The following is a description of a gene set: species: Mus musculus Genes positively differentially expressed in cell type: cDC2 (conventional dendritic cell type 2) upon treatment with cytokine: NP in mouse lymph nodes in vivo. Cytokines mediate cell-cell communication in the immune system and represent important therapeutic targets. A myriad of studies have highlighted their central role in immune function, yet we lack a global view of the cellular responses of each immune cell type to each cytokine. To address this gap, the authors created the Immune Dictionary, a compendium of single-cell transcriptomic profiles of more than 17 immune cell types in response to each of 86 cytokines (>1,400 cytokine-cell type combinations) in mouse lymph nodes in vivo. A cytokine-centric view of the dictionary revealed that most cytokines induce highly cell-type-specific responses. For example, the inflammatory cytokine interleukin-1β induces distinct gene programmes in almost every cell type. A cell-type-centric view of the dictionary identified more than 66 cytokine-driven cellular polarization states across immune cell types, including previously uncharacterized states such as an interleukin-18-induced polyfunctional natural killer cell state. Mouse Gene Set: CUI_CDC2_NEUROPOIETIN_RESPONSE_UP from publication Cui A, Huang T, Li S, Ma A, Pérez JL, Sander C, Keskin DB, Wu CJ, Fraenkel E, Hacohen N (PMID 38057668), and this is the list of marker genes: Ppp1ca, Gda (NCBI Gene Id 14544), Pkig, Ly6a, Hck, Tgfbi, Arpc1b, Cyp4f18, Ftl1, Cebpb, Lsm1, Cfl1, Nupr1, Lsm12, Ifi27l2a, Gng5 (G protein subunit gamma 5), Znfx1, Vcam1, Pitpnm1, Psmb3, Rnf187, Ly6i, Cdc26, Coro1b, Ly6e, Gapdh, Atp6v1g1, Ninj1, Sdc3, Lpcat2, Oas1a (NCBI Gene Id 246730), Aip, Vav1, Vta1, Clec4n, Prdx5, Gfer, Pdlim4, Myd88, Tmem86a, Ccl21a, Ptpn1, Nr1h3, Tmem51, Il4ra, Ifi204, Serinc3 (NCBI Gene Id 98830)